Given this list of marker genes NF1, POLR1HASP, CMKLR2, PCDHGB7, PIK3C2A, KLRC4, CPB2, KRT34, ISL1, PTPN20, RAD51D, P2RY10, NRXN1, VKORC1, ETV3, KRT33A, ADAMTSL3, TRIM24, OSBP, FBXL4, OR10H3, SLC4A3, CAMK4, GRIK1, SLC33A1, IL11RA, SERPINA4, PDPN, POFUT2, BCL2L11, RUFY3, TTTY1, GPR171, KRT86, HTR3A, CYP2C19, RREB1 (NCBI Gene Id 6239), PART1, ZNF202, ATP8B1, PHLDB1, PDE4A, IFNA10, MLLT10, SLC46A3, HSD3B2, DBT, ERC2-IT1, NEB, WBP4, ERC1 (ELKS/RAB6-interacting/CAST family member 1), IFNA1 (NCBI Gene Id 89955), MON2, TRIO, ZBTB40, CDYL (NCBI Gene Id 9425), MC5R, SPA17, H3C6, GNPAT, RB1CC1, PAXIP1, GUCY2F, SGCD, COL4A4, TSSK2, USP46, PVR, SUPT3H, MAGEC1, MAGEA8, IRS2, PLA2R1, ACKR1, EDIL3, PAPPA2, TANC2, SLC17A3, DOCK1 (NCBI Gene Id 1793), GTSE1, IFT27, JADE3, MAPT, MSH3, ATF2, COX6A2, IQCK, BMP10, EN2, PRELID3A, STAC, CCL16, ASB4 (NCBI Gene Id 51666), DNAJC16, PLPPR4, TMEM26, OPRL1, FZD5, MSL3, PAX9, CTRL, PGM3, CD8A, ZNF500, KCNA5, SRPK3, KRR1, TFDP2, PPP1R12B (protein phosphatase 1 regulatory subunit 12B), HOXD4, CDC73, ULK2, EXOC4, PLEKHB1, PTPRB, ZNF200 (zinc finger protein 200), DRD1, PAX6, PIK3CB, LORICRIN, PPP2R5B, ABCB1, ABO, GABRB2, PHOX2B, TSPAN2, AQP7 (aquaporin 7), CCR3, SCN7A, ZBTB14, OR2B6, POU6F1, NXPE3, CYP2D6, R3HCC1L, STARD5, SYT5, HABP4, GPR18, CACNA2D1, IGKV7-3, DMD, LY9, VSTM4, NR0B2, SPRR2C, RGS7, CACNB1, NTNG2, LPGAT1, PRKCA, FIG4, FUT1, CALN1, SULT4A1, SPATA2, SIM2, KNG1, COL19A1, ABCB9, TIE1, MAP3K1, PPP1R1A, NR1I2, CEP162, ABCC8, IVL, MAGEA9, COQ7, IL16, CYP2E1, COL8A1, TBX19, ADCY3, ZNF134, SLC4A8, PCM1, FRY, ZNF133, NR2F1, MPZL1, ELAVL2, GPR15, MAP2, COLGALT2, POU6F2, MAGI1, KRT2, CASP10, ZP2, NOS2, AMOT, IFNA8, S100A5, GABRA1, PDE4DIP, DRC3, FGF2, ZNF33B, AFF2, ST8SIA1 (ST8 alpha-N-acetyl-neuraminide alpha-2,8-sialyltransferase 1), PDE4D, NPAS2, SLC6A2, SLC22A6, CACNA1C, FGF18, COL14A1, GNG4, FPR2, CADM4, ATP6V0A2, IFNA14, IPO9, CHRNB4, GCM1, TENM4, NHEJ1, ENTPD3, ITIH3, PKP1, GRIK5, MFN1, ZNF141, NOTCH4, RPS6KA5 (NCBI Gene Id 9252), PRIM2, HNF1A, TPD52, GLE1, UPK1A, MEOX2, NPFF, ATXN3, SLC26A4, MYL3, NOVA1, LECT2, ERCC4, NFAT5, OCM, BRD4, MINDY2, C1orf216, PSG1, FAS, SGPL1, KCNJ6, BNIP1, RYR3, CRHR1, CYP11A1 (cytochrome P450 family 11 subfamily A member 1), LGI1, SLC15A1, CFH, POLR2K, ZSCAN26, SLC16A5, TBC1D22A (NCBI Gene Id 25771), FNTB, F2RL3, SCAMP1, AOC4P, LILRA1 (leukocyte immunoglobulin like receptor A1), LTBP4, OPLAH, CLCN3, ZNF157, DGCR5 (DiGeorge syndrome critical region gene 5), GPR19, GPLD1, SYNJ2, GLRA3, ADAM20, SIX6, PDCD1, NR3C2, PAX7, NMT2 (N-myristoyltransferase 2), JRKL, NRTN, ARL3, BRCA1, GJB5, ABCB10, IL13, ITGBL1, ZNF266, MDM2, PDE6A, NDP, HTR1E, CXCL5, KDR, EXOC6B, SURF2, MAP2K7, SULT2B1, RXRG, HCRTR2, ITIH1, RORB, NRP2, CDH4, CELA2B, HOXC11, CEACAM4, FOSL1, TBXT, PPM1E, GCA, AMMECR1, MYT1, PHF10, SLC18A1, CPEB3, FSHR, EPHB2, CYP4F2, APOBEC1, RUNX2, here is a description of the gene set: Neighborhood of ERCC4 species: Homo sapiens Human Gene Set: MORF_ERCC4 Neighborhood of ERCC4 excision repair cross-complementing rodent repair deficiency, complementation group 4 in the MORF expression compendium